Given this list of marker genes Arhgef15, Arf4 (ADP-ribosylation factor 4), Lin7b, Efna1, Lrfn3, Rbmx, Ntrk3, Amigo3, Rhog, Rhob, Dock4, Homer1, Etv5, Dnm1l, Slitrk6, Dab1, Mapk14, Neurod2, Hspa8, Ephb3, Caprin2, Dtnbp1, Lrrk2, Ppp1r9a, Dvl1, Cdk5r1, Adgrb3, Ube3b, Caprin1 (cell cycle associated protein 1), Rtn4r, Gsk3b, Lrp4, Fgf22, Itpka, Cd47, Sipa1l1, Cyfip2, Nedd4, Adgrl2, Cbln1, Ghsr, Kalrn, Sparcl1, Pick1, Shank3, Dmpk, Lrp8 (NCBI Gene Id 16975), Oxt, Rhoa, Lzts1, Dock10, Hnrnpk, Cdc20, Taok2, Ptprd, Mecp2, Adgrb2, S1pr2, Stau2, Asic2, Arc, Ptn, Nrxn1, Dctn1, Strn4, Abi3bp, Il10, Nefl, Il1rapl2, Tuba1a (NCBI Gene Id 22142), Rac3, Mdga1, Ephb2, Arhgap33, Rock2, Slc17a7, Nectin1, Epha7, Lrrtm4, Lingo4, Mdga2 (MAM domain containing glycosylphosphatidylinositol anchor 2), Opa1 (OPA1, mitochondrial dynamin like GTPase), Neurl1a, Igsf11, Malat1, Rap2a, Pcdh8, Elavl2, Sema4d (NCBI Gene Id 20354, sema domain, immunoglobulin domain (Ig), transmembrane domain (TM) and short cytoplasmic domain, (semaphorin) 4D), Baiap2, Ins1, Ptk2b, Lin7a, Pgrmc1, Fzd1, Slc30a1, Slc17a6, Srpx2, Pten, Slitrk3, Dag1, Nedd4l, Lrfn4, Zfp804a, Cbln2, Asap1, Ywhaz, Cdh8, Actr3, Vps35, Prkca, Dcx, Lrrn1, Adgre5, Nlgn1, Cap2, Dclk1, Camkv, Slc17a8, Srgap2, Setd5, Zdhhc17, Itgb1, Snap25, Pak3, Rps6ka5, Snca, Fam107a, Ppp1r9b, App, Dlgap4, Cacna2d3, Dnm3, Numb, Bdnf, Dgkb, Zdhhc15, Srcin1, Psen2, Chmp2b, Gna13, Nrcam, Crtac1, Fgf7, Adgrl1, Sema7a, Arhgap22, Tsc2, Amigo1, Flrt1, Lrrtm1, Htr4, Lrrc4b, 2610042L04Rik, Sarm1, Ctnnb1, Lrrc24, Nckipsd, Cdc42, Dlg4, Nrp2, Epha4, Crmp1, Oxtr, Lin7c, Lrtm2, Lrrn3, Cntnap4, Vldlr, Adgrl4, Dbn1, Abhd17a, Vhl, Cux2, Lrtm1, Magi2, Negr1, Caskin1, Ogt, Marcks, Efna5, Ntrk1, Cdkl5, Frmpd4, Sema4a, Gpr158, Dip2a, Rock1, Pdxp, Slitrk2, Il1rap, Lrfn5, Lrrtm2, Cask, Gpm6a, Ins2, Numbl, Colq, Six4, Wnt5a, Farp1, Ube2v2, Adam10, Pik3r1 (phosphoinositide-3-kinase regulatory subunit 1), Musk, Zdhhc8, Wasl, Klk8, Rapgef2, Ncan, Rims3, Picalm, Lrrtm3, Pdlim5, Lrfn2, Cntnap1, Tanc2, Flrt2, Amot, Anapc2 (anaphase promoting complex subunit 2), Chrnb2, Cln3, Dab2ip, Gpc4, Mef2c, Plxnc1, Fyn, Camk2b, Adgrb1, Sema3f, Pafah1b1, Tlr2, Mark1, Nf1 (NCBI Gene Id 320618), Ppfia2, Snx27, Usp9x, Gripap1, Kif5b, Ptk2, Eef2k, Mfn1, Dkk1, Abl1, Adnp, Igsf9, Sigmar1, Syndig1, Cfl1, Ptpn1, Abi2, Arhgap44, Ptpn13, Wnt7a, Ptprf, Dock1, Ago2, Zmynd8 (NCBI Gene Id 99150), Septin11, Vangl2, Tanc1, Cpeb3, Rims4, Kcnk13, Chrna7, Chd4, Nrn1, Mark2, Il10ra, Mycbp2, Dhx36, Nrg1, Ptprt, Efnb3, Myo5b, Slitrk1, Ghrl, Slit1, Ntng2, Psd, Abi3, Prickle1, Cttnbp2, Srgap3, C1ql3, Six1, Clstn3, Rac1, Nlgn3, Ctnna2, Hnrnpm, Ngef, Carmil3, Prmt8, Tpbg, Rtn4, Thbs2, Vstm5, Prickle2, Grid1, Eif4g1, Actr2, Disc1, Ube3a, Icam5, Rheb, Reln, Cyp19a1, Shank2, Grin1, Abhd17c, Nrxn2, Cdh2, Psen1, Nedd8, Tnf, Cript, Iqsec1 (IQ motif and Sec7 domain 1), C1ql2, Tubb5, Pum2, Lrfn1, Nedd9, Kif1a, Sparc (NCBI Gene Id 20692), St8sia2, Xlr3b, Ube2m, Ntrk2, Cdk5, Iqsec2, Dbnl, Cyfip1, Slit2, Nfatc4 (nuclear factor of activated T cells, cytoplasmic, calcineurin dependent 4), Arf6, Ntn1, Lzts3, Ror2, Trim47, Ptprs, Bhlhb9, Agrn, Afdn, Plppr4 (NCBI Gene Id 52835), Slitrk5, Camk1, Nrg2, Ptpro, Mfn2, Abhd17b, Clstn2, Clstn1, Sema4c, Drd2, Dact1, Robo1, Flrt3, Amigo2, Slc12a5 (NCBI Gene Id 57138), Map1b, Pdzd11, Fcgr2b, Syngap1 (synaptic Ras GTPase activating protein 1 homolog (rat)), Slitrk4, Tiam1, Nlgn2 (NCBI Gene Id 216856), Rab17, Myh10, Grid2, Fgfr1, Ephb1, Dlg5, Slc7a11, C1ql1, Rapgef4, Akt1, Grin2b, Il1rapl1, Nae1, Lhfpl4, Apoe, Egln1, Snap91, Prnp, Nectin3, Slc18a3, Elmo1, Vcp, Lats1, Trem2, Adgrl3, Asic1, Itsn1, L1cam, Podxl, Lingo2, Cc2d1a, Wnt3a, Iqgap1, Sybu, here is a description of the gene set: Any process that modulates the physical form or the activity of a synapse, the junction between a neuron and a target (neuron, muscle, or secretory cell). studied in species Mus musculus Mouse Gene Set: GOBP_REGULATION_OF_SYNAPSE_STRUCTURE_OR_ACTIVITY